The following is a description of a gene set: Talipes calcaneovalgus Human Gene Set: HP_TALIPES_CALCANEOVALGUS species: Homo sapiens Talipes calcaneovalgus is a flexible foot deformity (as opposed to a rigid congenital vertical talus foot deformity) that can either present as a positional or structural foot deformity depending on severity and/or causality. The axis of calcaneovalgus deformity is in the tibiotalar joint, where the foot is positioned in extreme hyperextension. On inspection, the foot has an \up and out\ appearance, with the dorsal forefoot practically touching the anterior aspect of the ankle and lower leg., and this is the list of marker genes: ALDH18A1, LMX1B, FBLN5, CHRNG, VIPAS39 (VPS33B interacting protein, apical-basolateral polarity regulator, spe-39 homolog), ELN, PLA2G6 (phospholipase A2 group VI), PMP22, ERMARD, SPECC1L, DHCR7, NEFL, ATRX, VPS33B (VPS33B late endosome and lysosome associated)